Given this list of marker genes Ercc3, Polr2l, Polr1c, Polr2e, Polr2k, Polr1e, Polr2f, Taf1d, Ercc2, Polr1g, Ccnh, Polr1h, Gtf2h2, Gtf2h4, Tbp, here is a description of the gene set: electronically inferred by orthology from the curated human pathway Reactome Pathway: RNA Polymerase I Promoter Escape This event has been computationally inferred from an event that has been demonstrated in another species.<p>The inference is based on the homology mapping from PANTHER. Briefly, reactions for which all involved PhysicalEntities (in input, output and catalyst) have a mapped orthologue/paralogue (for complexes at least 75% of components must have a mapping) are inferred to the other species. part of: RNA Polymerase I Promoter Clearance studied in species Mus musculus